The following is a description of a gene set: studied in species Homo sapiens Human Gene Set: HP_POTTER_FACIES A facial appearance characteristic of a fetus or neonate due to oligohydramnios experienced in the womb, comprising ocular hypertelorism, low-set ears, receding chin, and flattening of the nose. Potter facies, and this is the list of marker genes: AGT, PKHD1 (NCBI Gene Id 5314), NPHP3, AGTR1, ITGA8, UBA1, ACE, PBX1, PAX2, CEP55, GFRA1 (NCBI Gene Id 2674), FGF20, REN